The following is a description of a gene set: species: Homo sapiens A process of protein insertion of multi-pass membrane proteins into the endoplasmic reticulum (ER) membrane. Insertion of multi-pass membrane proteins is mediated by the multi-pass translocon complex and takes place following membrane insertion of the first few transmembrane segments of proteins by the SEC61 complex to promote insertion of subsequent transmembrane regions. Human Gene Set: GOBP_MULTI_PASS_TRANSMEMBRANE_PROTEIN_INSERTION_INTO_ER_MEMBRANE, and this is the list of marker genes: NCLN, NOMO3, RAB5IF, TMEM147, WDR83OS, CCDC47, NOMO1, NOMO2 (NODAL modulator 2), TMCO1